The following is a description of a gene set: species: Mus musculus Enables the transfer of alanine from one side of a membrane to the other. Alanine is 2-aminopropanoic acid. Mouse Gene Set: GOMF_ALANINE_TRANSMEMBRANE_TRANSPORTER_ACTIVITY, and this is the list of marker genes: Slc6a14, Slc36a2, Slc38a7, Slc1a4, Sfxn1, Slc3a2, Slc36a1, Slc38a3, Slc38a2, Slc7a8, Slc6a6, Slc38a1, Slc36a3, Slc36a4, Slc38a4, Slc38a5